The following is a description of a gene set: Human Gene Set: MIR6853_5P species: Homo sapiens Genes predicted to be targets of miRBase v22 microRNA hsa-miR-6853-5p in miRDB v6.0 with MirTarget v4 prediction scores > 80 (high confidence targets). from publication Chen Y, Wang X (PMID 31504780), and this is the list of marker genes: SLC2A3, NLGN2, XKR6 (NCBI Gene Id 83654), FJX1, KRTAP5-10, SLC2A14, FLT4, PPIL1